Given this list of marker genes TPM2, TNNT1, MATN3, CHST3, ERI1, PIEZO2, NFIX (NCBI Gene Id 4784), here is a description of the gene set: studied in species Homo sapiens Human Gene Set: HP_DECREASED_HIP_ABDUCTION Reduced ability to move the femur outward to the side. Decreased hip abduction